Given this list of marker genes Ret, Ppp3ca, Ednra, Agtr2, Myc, Foxd1, Wnt4, Pax2, Nog, Sox9, Sox8, here is a description of the gene set: species: Mus musculus Mouse Gene Set: GOBP_POSITIVE_REGULATION_OF_KIDNEY_DEVELOPMENT Any process that increases the rate, frequency or extent of kidney development. Kidney development is the process whose specific outcome is the progression of the kidney over time, from its formation to the mature structure. The kidney is an organ that filters the blood and excretes the end products of body metabolism in the form of urine.